Given this list of marker genes Serpinh1, Serpina10, Serpina1a, Pebp1, Serpina3a, Serpinb1b, Itih5, Serpina1d, Spink8 (NCBI Gene Id 78709), Serpinb12, Serpina1c, Hrg, Crim1, Agt, Serpinb1a, Serping1, Serpini1, Serpinb9, Pcsk1n, Serpina9, Serpinf1, Col28a1, Serpina5, Slpi, Cd109, Serpina3m, Spink6, Serpinb6c, Ambp, Itih2, Serpinb13, Mug1, Serpinb6d (serine (or cysteine) peptidase inhibitor, clade B, member 6d), Serpinb3b, Spink13, Wfdc17, Wfdc18, Spink7, Serpina6, Wfikkn1, Serpini2, Serpine3, Anxa2, A2m, Serpinb9f, Serpinb6b, Serpinb10, Spink11, Tfpi2, Spink1, Spink12, Spint3, Aplp2, Wfdc6a, Wfdc9, Mug2, Col6a3, Itih4, Pbp2, Serpinb2, Serpina16, Spink10, App, Eppin, Wfdc11, Wap, Serpind1, Serpina1b, Wfdc6b, Serpine2, Serpina3b, Serpina3c, Serpinb9c, Serpina1f, Wfdc2, Serpinb6e, Spint1, Reck, Serpinf2, Serpinb7, Serpina3j, Spint2, Serpina3k, Serpinb3c, Wfdc12, Serpina3g, Spink5, Serpina7, A2ml1, Spink2, Serpinb3d, Wfdc8, Col7a1, Wfdc5, Mansc4, Serpine1, Spink4, Wfdc10, Serpinb1c, Serpinb11, Wfdc3, Papln, Pzp, Wfdc13, Furin, Serpinb9g, Serpina3i, Tfpi, Itih3 (inter-alpha trypsin inhibitor, heavy chain 3, NCBI Gene Id 16426), Itih1, Serpinb9b, Wfdc21, Serpinc1, Serpinb5 (serine (or cysteine) peptidase inhibitor, clade B, member 5), Wfdc16, Serpina12, Serpinb9d, Wfikkn2, Serpina1e, Serpinb3a, Spint4, Serpinb9e, Serpinb8, Wfdc1, Wfdc15b, Serpina11, Serpinb9h, Serpina3f, Wfdc15a (NCBI Gene Id 68221), Serpinb6a, Serpina3n, here is a description of the gene set: Binds to and stops, prevents or reduces the activity of a serine-type endopeptidase. species: Mus musculus Mouse Gene Set: GOMF_SERINE_TYPE_ENDOPEPTIDASE_INHIBITOR_ACTIVITY